The following is a description of a gene set: species: Homo sapiens Any process that decreases the amount of urine excreted from the body over a unit of time. Human Gene Set: GOBP_NEGATIVE_REGULATION_OF_URINE_VOLUME, and this is the list of marker genes: SLC4A1, AVPR2, OXT, ADCY6, MLLT6